The following is a description of a gene set: The chemical reactions and pathways resulting in the breakdown of glycosyl compound. studied in species Mus musculus Mouse Gene Set: GOBP_GLYCOSYL_COMPOUND_CATABOLIC_PROCESS, and this is the list of marker genes: Aicda, Dpyd, Upb1, Fuca2, Gda, Cda, Naga, Abhd10, Dera, Pnp2, Nudt1, Dctd, Fuca1, Upp2, Ahcyl, Gba2, Uox, Gla, Pnp, Urad, Ada, Urah, Upp1, Xdh, Pycr3, Gba1, Ahcy, Enpp4, Adal, Cdadc1